The following is a description of a gene set: Any process that activates or increases the frequency, rate or extent of striated muscle cell differentiation. species: Homo sapiens Human Gene Set: GOBP_POSITIVE_REGULATION_OF_STRIATED_MUSCLE_CELL_DIFFERENTIATION, and this is the list of marker genes: ARRB2, RBM24, TGFB1, MIR1-1, MIR133B, EDN1, MYOG, CAV3, PIEZO1, MYOD1, TRIM32, MYLK3, MIR133A1, MTOR, MIR208A (microRNA 208a), MIR206, SHH, MESP1, ATP11A, IGF1, BCL2, MEF2C, MAPK14, PRKD1, LMOD3, MYF5, PARP2, MIR199A1, MYF6, MAML1, MAMSTR, SMYD1, HOPX, MIR204 (microRNA 204), SHOX2, BMP4, AKAP6, MIR499A, MYOCD, MMP14, PROX1 (NCBI Gene Id 5629), MIR19A, ACTN3, NRG1, BMP10, TBX1, CYP26B1, EFNB2, WNT3A, KAT2A, MIR19B1